The following is a description of a gene set: The change in morphology and behavior of a mature or immature T cell resulting from exposure to an antigen for which its T cell receptor is specific bound to an MHC molecule on an antigen presenting cell, leading to the initiation or perpetuation of an immune response. Mouse Gene Set: GOBP_T_CELL_ACTIVATION_VIA_T_CELL_RECEPTOR_CONTACT_WITH_ANTIGEN_BOUND_TO_MHC_MOLECULE_ON_ANTIGEN_PRESENTING_CELL studied in species Mus musculus, and this is the list of marker genes: Sema6d, Icam1, Cd81, Lgals3, Havcr2, Itgal, H2-DMb2, Fgl2, Tyrobp, Trem2, Apbb1ip, Plxna1 (NCBI Gene Id 70046), H2-DMb1